Given this list of marker genes ITGB1, IER3, GADD45A, PAM, PIM1, CFB, CYFIP2, RPS12, ACSL1, MLF2, UGT1A6, HIVEP2, GAS1, B3GALT1 (beta-1,3-galactosyltransferase 1), SLC11A1 (NCBI Gene Id 6556), TMSB4X, GAA, YME1L1, SUMO1, TCTA, AKT2 (NCBI Gene Id 208), CD151, REN, CSPG4, DDX5, PRLR, GPC1, ARHGEF7, NUCB1 (NCBI Gene Id 4924), SP3, PTPA, SEPTIN4, GTF2H2, ACP5, CANX, OAS1, CHAF1B, CDKN1A, SYNJ1, ARF4, CALD1, CD47, IL1RAP, IFIT1, MCC, ADM, AQP1, PAK2, PEA15, CDKN2B, THY1, NXN, CKAP2L, CDKN1B, SDCBP, BDNF, SERPINB1, MYO1B (NCBI Gene Id 92451), NMT1 (N-myristoyltransferase 1), VCAM1, VLDLR, SLC4A1, PMAIP1, POM121, MGP, PTPRN, COL3A1, FOSL2 (FOS like 2, AP-1 transcription factor subunit), VEGFD, SCAMP1, CSTB, PYCR1, AKAP12, CTBS, TRIM31, FBLN5, MT1A, BRD2, MYL12A, PLS3, APP, RABIF, SPARC, SUCLA2, SPTAN1, CAST, PERP, VAMP3, LAMC1, PDLIM7, MYO1C, IGF2R, AKT1, MAN2B1, ITGAL, NPRL3, CSDE1, GOLGA2, ZXDB, SLC2A5, TCN2, IRAG2, GCN1, KLF4, ATRX, CD48, RPS23, CCNH (cyclin H), UBE2V1, F3, IMPACT, CXCL10, HBEGF, TMEM126A, PPP2R5E, UBE2L3, RAB2A, GLT8D1, TGFBR2, COL1A2, ILK, FCGRT, RAB10, IFI35, PLAC8 (placenta associated 8), SERPINE1, PHLDB1, MAPK3, GM2A, SERINC3, RARA, ALDH9A1, MAP3K1, PPP1R15A, CPD, PDGFRA, COL5A1, PEX19, CCNG2, KLF7 (NCBI Gene Id 8609), ISCU, MSN, FOXN3, ARHGAP25, PMP22, SLC2A2, TIMP2, FAS, CRYAB (NCBI Gene Id 1410), ANXA6, TGFB1, CAVIN3, LOX, ITM2B, NPC2, COL1A1, ERBB2, FTL, IRF7, ID3, GPM6B, LYZ, RSAD2, INHBA, PPIE, MTREX, CAV1, DDB2 (NCBI Gene Id 1643), CASP1, RB1, TCHH, MAGI2, EDN1, A2M, LXN, CEBPA, VEGFA, CCN2, RRM2B, GADD45G, PLA1A, ALB, SCPEP1, GDI1, CDH2, HSPB1, NCAM1, FTH1, TPM1, CTSB, CCND1 (NCBI Gene Id 893), FSTL1, GBP2, FADS2, ID2, ERRFI1, UGT1A1, NPPB, MDM2 (NCBI Gene Id 84825), LAMP2, DGKZ, UGT2B15, F2R, SFXN3, TSPAN7, PLAUR, VARS1, DLEU2, DUSP1, ARPC4, PTPN1, PLD1, WFS1, DUSP6, SNCA (synuclein alpha), CD3E, ELAVL4, FN1, DNTT, ZFP36L1, TRIP12, ANXA4, HNRNPH1, SFN, NIBAN1, JPH2, LIMS1, CSK, FZD1, H3-3B, NREP, KIF14 (kinesin family member 14), VHL, COL6A3, OPRPN, PDGFB, ARVCF, CHP1, GABRG2, NDRG1, LAMP1, THBS1, ROCK1, HMOX1, DDIT3, MYC, PDGFRB, GLYR1, TSPO, CASP3, POSTN, here is a description of the gene set: Genes down-regulated by MYC, according to the MYC Target Gene Database. We report a database of genes responsive to the Myc oncogenic transcription factor. The database Myc Target Gene prioritizes candidate target genes according to experimental evidence and clusters responsive genes into functional groups. We coupled the prioritization of target genes with phylogenetic sequence comparisons to predict c-Myc target binding sites, which are in turn validated by chromatin immunoprecipitation assays. This database is essential for the understanding of the genetic regulatory networks underlying the genesis of cancers. Human Gene Set: DANG_REGULATED_BY_MYC_DN from publication Zeller KI, Jegga AG, Aronow BJ, O'Donnell KA, Dang CV (PMID 14519204) species: Homo sapiens